The following is a description of a gene set: Cutaneous syndactyly species: Homo sapiens Human Gene Set: HP_CUTANEOUS_SYNDACTYLY A soft tissue continuity in the A/P axis between two digits that extends distally to at least the level of the proximal interphalangeal joints, or a soft tissue continuity in the A/P axis between two digits that lies significantly distal to the flexion crease that overlies the metacarpophalangeal or metatarsophalangeal joint of the adjacent digits., and this is the list of marker genes: XYLT1, CTNND1, KAT6A, GPC4, BCOR, ATP9A, NOG, CDH3, BHLHA9, IQCE, HOXD13, FGF16, PAX3, WDR19, SC5D, TMEM53 (transmembrane protein 53), CDH11, PTDSS1, DHCR7, MYH8, GJA1, KCTD1, EP300, TMEM94, GPC3, CKAP2L, CREBBP, LRP4, CDC45, TWIST2, DSP, GRIP1, TWIST1, SMOC1 (NCBI Gene Id 64093), IRF6, SLC39A8, PRKD1, ATP6V1B2, DCHS1, FRAS1, MAP3K20, FGFR2, NECTIN1, SMARCAD1, TBC1D24, NSDHL, CACNA1C, ORC1, MYH3, PIK3CA, CEP55, SVBP, NECTIN4, SETBP1, RFX7, CHUK, MCTP2, GLI3, BICRA, CAMTA1, RBM10, FANCF, WDPCP, TRRAP, MEIS2 (NCBI Gene Id 56908), MECP2, CPLANE1, LMBR1, TBX5, BLTP1 (bridge-like lipid transfer protein family member 1), ANKRD11, RPL10, SOST, PORCN, FAT4, JUP, KIF7, SHH, ROR2, FREM2, SCARF2, DYRK1A, NEDD4L, PPP2R3C, RTTN, DDX59, CDH1, BBS2, SALL1, PIEZO2, EBF3, FIG4, MEGF8, GABRA3, CHSY1, H4C9, MAB21L2, DEAF1, FGFR1, TP63, EFNB1, CCBE1, FGF9